Given this list of marker genes TUBG1 (tubulin gamma 1), VPS13B, CNTNAP2, CCND2, HERC1, NONO, PIK3R2, CAMK2A, C12orf57, ODC1, PRMT7, SLC4A10, CNOT3, SZT2, TBC1D7, ATP1A2, ATP1A3, MAST1, KDM3B, here is a description of the gene set: Increased vertical dimension of the corpus callosum. This feature can be visualized by sagittal sections on magnetic resonance tomography imaging of the brain. Human Gene Set: HP_THICK_CORPUS_CALLOSUM Thick corpus callosum species: Homo sapiens